Given this list of marker genes RFX3, MAP9, SUMO4, ADAMTS5, CUL3, SENP7, PCLO, PPM1A, LEPROT, PDS5A, GPATCH11, ATPSCKMT, DNAL1, MEGF11, NUFIP2, MGA (MAX dimerization protein MGA), ARMC3, BLZF1, CCSER2, FLI1, PUM2, BACE2, CENPS, NRIP1, TMTC3 (NCBI Gene Id 160418), LCLAT1, RSRC2, FBXL17, MRPS7, CLOCK, E2F6, HS3ST3A1, SGPP1, C11orf54, MGAT4A, POLDIP2, EPHX4, TDRD7, PRPF38B, METTL9, NDFIP2, GAS2, SLC10A4, TM9SF3, ZNF507 (zinc finger protein 507), ABHD18, KCMF1, MRAS, ACP3, LUM, NR3C1, SAMSN1, GDAP1, ATP6V1G1 (ATPase H+ transporting V1 subunit G1), PEX5L, MECP2, HTR1F, MGARP, ONECUT2, CETN3, CKAP5, ZNF326, MRPL42, CAPS2, DDHD1, LUZP2, COBLL1, SUMO2, ZNF131, PIAS1, LDB2, SPIN1, PDE12, RGS5, HOOK1, ITGB8, DCP2, CNTNAP2 (contactin associated protein 2), ODF2L, ZNF670, UBE2O, TCAIM, EIF4A2, RBM38, RTL3, ICA1L, MFSD4A, YIPF6, TSHZ3, TRIM33, YTHDF3, MAP7, PAPOLB, SLC7A11, WDR72, PXYLP1, RIOK3, KCNMA1, CPNE3, NECAB1, FAM169A, PJA2, MTSS1, RC3H1, B3GNT5, CRISPLD1, FNDC3A, TMEM38B, HEXIM1, DDX42, GDAP2, HACE1, SCAF11, LRRCC1, NEXMIF, PRPF40A, LARP4, ARGFX, DGKH, MOB1B, FAR2, CEBPZOS, CAV1, HDGFL3, GRB10, SINHCAF, VEGFA (vascular endothelial growth factor A), CERK, ZEB1, NBPF1, TNFRSF11B (TNF receptor superfamily member 11b), RNF138, ACVR1B (activin A receptor type 1B), ZDHHC21, TMEM196, SOHLH2, PIMREG, NDST3, FUT4, WWP2, PGGT1B, LONRF2, NFAT5, GRIN2A, POU2F1, APH1B, ARHGAP11A, JADE2, PWWP3B, CCDC39, KCTD4, PLRG1, CDK6, SLC4A7, NALCN (NCBI Gene Id 93074), PLCL1, PCDHB2, MYO5B (myosin VB), THRAP3, ADAMTS3, ACSL3, ENY2, EGF, TASOR, BOLL, GRM3, DBT, ITGBL1, STAU2, LRP2, ANKRD29, FREM1, C4orf46, ERICH3, FZD3, SYTL2, SIX2, STXBP3, ENKUR, MACIR, F9, PLEKHA8, IPMK, MSX2, PCGF5, CXADR, CDCA4, CLTC, CFAP97, NR3C2, EFNA5, C10orf88, IGF2BP2, LAMTOR3, PDXDC1, ZNF770, AHR, FSTL5, IL6ST, SLCO4C1, SNX10, ZFP82, FMR1, CYYR1, SLC6A14, PER2, ZHX1, SLC5A12, TRDN, AVL9, ZNF805, VTA1, PNRC2, ZDHHC17, TMEM33, GAB1, NFXL1 (nuclear transcription factor, X-box binding like 1), TRIM23, ETNK1, ZNF181, INSIG1, S1PR3, GCFC2, NAMPT, CIP2A, USP47, TXNDC16, NCKAP5, TOX, HDAC9, YBX1 (Y-box binding protein 1), CUX2, RBL2 (RB transcriptional corepressor like 2), LPP, NLK, ARHGAP5 (NCBI Gene Id 394), MSANTD3, SLC16A7, GCLM, ITGA6, GOPC, RBAK-RBAKDN, IGDCC4, IKZF5, VIRMA, CCDC148, CD164, ZNF273, ITGA4, KLF3, CMYA5 (cardiomyopathy associated 5), MMGT1, GOLIM4, C1GALT1C1L (NCBI Gene Id 731364), HBS1L, HCFC2, ZNF850, DIAPH3, TOMM70, MIPOL1, PCDH10, FMN1, SCAI, SP4, ZMAT3, ASPH, BCAT1, HPRT1, SI, ZFHX4, HIPK1 (NCBI Gene Id 23323), AK7, CD38, NCK1, AGGF1, KLF10, BRWD3, LYSMD4, DCLK1, AHI1, GASK1B, APPL1, PCDH17, RAB11A, FBXO42, TMF1, EFCAB11, FUT9, ENAH, NECTIN3, DSE, CDK17, IRAK3, AQP4, CDH11, FDX1, FGF2, KRR1, TMPO, ZC3H12C, N4BP2, ITPRID2, KAT6A, WDR33, RB1, ANKRD28, C21orf91, AFTPH, NF1, REEP3, TMEM14A, CHIC1 (cysteine rich hydrophobic domain 1), TULP4, KCNQ5, LINC01517, TRIP11, ZFP30 (ZFP30 zinc finger protein), CAPZA2, GRM5, ACTR2, HYCC2, ZNF146, THAP5, CA8, CAMK4, CISD2, RBMS3, NR4A3, LY6K, SORL1, UBR3, FAXC, CAST, LAMP2, POLR1D, SKIL, COMMD6, BMP2, PTPN4, NPR3, KCNA4, CADM2, MMP20, SLC9A4, TTC3, NCEH1, ZFX, GOSR1, here is a description of the gene set: Genes predicted to be targets of miRBase v22 microRNA hsa-miR-576-5p in miRDB v6.0 with MirTarget v4 prediction scores > 80 (high confidence targets). from publication Chen Y, Wang X (PMID 31504780) Human Gene Set: MIR576_5P studied in species Homo sapiens